The following is a description of a gene set: Human Gene Set: MIR3681_3P Genes predicted to be targets of miRBase v22 microRNA hsa-miR-3681-3p in miRDB v6.0 with MirTarget v4 prediction scores > 80 (high confidence targets). species: Homo sapiens from publication Chen Y, Wang X (PMID 31504780), and this is the list of marker genes: SLC22A23, HMBOX1, CEP76, HECTD1, UBE2N, HOXA5, DISC1 (DISC1 scaffold protein), GRIA3 (glutamate ionotropic receptor AMPA type subunit 3), XPR1, SP2, CCDC88A, LHFPL3, SKA3, FRMPD3, GXYLT1, ZNF800, KCNN3, SMARCA2, ARID1B, GREM1 (gremlin 1, DAN family BMP antagonist), RAB20, PTPN9, CNOT6, UBR5, CCDC92, RND3, SAMD12, MINPP1, IFITM10, PPP4C, POGZ, VANGL2, EHF, HAPLN1 (hyaluronan and proteoglycan link protein 1), TXNIP, GCC2, HYCC2, FOXA3, ECE1, PDS5B, TCEA1, TTC39A (NCBI Gene Id 22996), FAM177A1, MAPK14, GALNT3, SLC35F1, RETREG3, SLC6A1, IGSF3, MTCL2, ABL2, NRXN1, AMD1, PAX9, UGCG, RERE, NEO1, GPATCH2L, NFX1, ARHGAP21, TMEM64, MED12L (mediator complex subunit 12L), NEK2, SAMD10 (sterile alpha motif domain containing 10), MAPKAPK3, NALF1, UNC13C, GPAM, TRIM23, IGLON5, SCAF11, NDST1, ASPH, FBLN2, ZFP82, RYBP, CKAP4, PDE3A, ZFP36L1, TNPO1, LBH, STRN4, AK2, WDR7, SETD7, CLPP, TEAD1, UBE2W, MLLT10, KCNK10, FAM184A, PLK2, SPTY2D1, ERC2, GATA6, BEND4, COPB2, MNT, PDHX, FNDC4, EPB41L1, CSF1, DOT1L, SPATA17, SSH1, MATN3, MTSS2, ANKRD40, TMEM30A, MET, NAA50, CTDSP2, HCN4, PLCH1, CXADR, GALNT7, FBLN5, SH3BGRL2, MOSMO, USP46, MIEF1, SOCS5, SMAP1, TUB, SEC61A1, STK35, ADCY2, PTPRB, FXR2, NPTXR, NF1, MBTD1, UNC80, APOLD1, ZFHX3, VEGFC, SORL1, FRYL, VPS4B, C1QTNF7, PALS2, STIM2, FBXW7, AMER2, SH2D3C, NRBF2, RNF38, MCF2L, RELN, SERTAD2, ARMC8, TNFRSF10D, RSBN1L, DCP1A, PPFIA2, NEMP2, COMMD3-BMI1, ISL1, ROR1, SLC35F3, BAZ2B, ARHGEF38, KIRREL1 (NCBI Gene Id 55243), PHB1, NRK, KLHDC8A, ARRDC4, ZKSCAN2, KMT2A, ADAMTS5, MED14, NFIL3, ZNF652, RCOR3, OTULIN, NREP, CDH24, PRKX, RET, KDM7A, MSL1, MAP2K7, AFF3, NEUROD6, TTC9, RHOT2, GTF2A2, AFF4, MED13, UBN2, IRS1, ITPKC, LITAF, LTBP1, PAIP2, WEE1, ENAH, ERLEC1, UTP15, TMTC2, SASH1, DCUN1D4, TPPP, TMC7, KAT7, MTMR4, ECE2, DNAAF6, COL21A1, EPHB2, SOS1, NABP1, RO60, FBXO30, HIP1, KBTBD11, DTX4, UGT8, MSI2, PHF6, PTPRT, SGMS1, HYCC1, MYT1, HIC1, DCC, CYP39A1, IL13RA1, EEF1AKMT4-ECE2, RPS6KA5, ARF3, ZC3H12D, BICC1, ARHGAP32, MIPOL1, NALF2, PLAGL2, SLC39A7, USH2A, GCC1, MDH1B, PLCL2, CHTF8, SLIT2, CREB1, OSBPL10, SNX12, UBE2E2, ZNF704, NUS1, H3-3B (NCBI Gene Id 3021), EML1, CA10, TRIL, ZNF618, ATXN10, ARHGAP12, ALDH4A1, MAPK8IP3, KDM3A, DPY19L3 (dpy-19 like C-mannosyltransferase 3), MDN1, NSD1, PPME1, SCAI, TMEM87A, CDS1, CEMIP (NCBI Gene Id 57214), ITGA5, RNF182, MARK4, MMD, SS18, GSPT1, COL27A1, SLC24A4, PDE10A, BMI1 (NCBI Gene Id 648), PCNX1, SP1 (Sp1 transcription factor), SLC5A3, CACNA2D3, SEC24A, VANGL1, GIGYF2, NAV2, CECR2, WNK1, EYA4 (NCBI Gene Id 56002), RGL2, PTPRQ, PROSER2, KCNK2, GABBR2 (gamma-aminobutyric acid type B receptor subunit 2), UBA6, RPS6KB1, SREK1 (NCBI Gene Id 57833), GRIK3, IRF4, PGAP1, STK24, PDE7B, COLGALT2, GAB1, CCNT2, N4BP1, CACNG2, FAM78A, C1orf21, DPY19L4, PDIA5, GRIA4, SZRD1, ATP8A1, PDPK1, NXT2 (nuclear transport factor 2 like export factor 2), RECK, SIRT1, STARD4 (NCBI Gene Id 154899), RNF144A, PPM1E, STOX2, RAP1B, STX7, AKIRIN1, OPA1, DIRAS1, MEGF11, TMEM167A, TMEM25, GRIN2D, CDIP1, CASC3, SYT1, RETREG1, H3-5 (H3.5 histone), STK32A, EIF2S2, ABHD17C, INO80D, ABCB9, MED13L, CCNC, SNAP25, RNGTT, AKR7A2, SH3RF1, NGFR, GLTP, BCORL1, LYPD3, RASGEF1B, SEC22A, MME, TGFBR1, ST6GALNAC3, EFR3A, EPB41L4A, PHF24, YWHAB, DCX, CRKL, F3, SRGAP2, BAG2, CABLES2, DNAAF9, TRPV3, FEM1B, USP49, USP42, AK4, MTDH, RAB11FIP1, PNKD, KCTD4, SFXN2, SLC7A11, POGLUT1, ABCA12, SOX7, SPG21, ING5, MBOAT2, GRM5, B3GNT7 (NCBI Gene Id 93010), REPS1, GSK3B, JAG1, UBR1